The following is a description of a gene set: Human Gene Set: GOMF_INTRACILIARY_TRANSPORT_PARTICLE_B_BINDING studied in species Homo sapiens Binding to an intraciliary transport particle B (IFT B) complex., and this is the list of marker genes: IFT70A, KIFAP3, KIF3B, IFT56, IFT70B